The following is a description of a gene set: Human Gene Set: GOBP_MORPHOGENESIS_OF_AN_EPITHELIAL_FOLD studied in species Homo sapiens The morphogenetic process in which an epithelial sheet bends along a linear axis., and this is the list of marker genes: OVOL2, FGFR2, TP63, NOG, SULF1, HOXD13, BMP7 (NCBI Gene Id 655), AR, NODAL, GDF7, WNT5A, LUZP1, WNT2 (NCBI Gene Id 7472), SOSTDC1, CECR2, CFL1, RDH10, HIF1A, EGFR, FGF10, CTNNB1, SHH, WNT2B (NCBI Gene Id 7482), BMP4, BMP5